Given this list of marker genes GAB1, HGF, GRB2, PIK3CA, PIK3R1, MET, here is a description of the gene set: MET binds and phosphorylates the adapter protein GAB1, thus creating a docking site for the regulatory subunit PIK3R1 of the PI3K complex. Recruitment of PI3K to MET-bound phosphorylated GAB1 results in PI3K activation, production of PIP3, and stimulation of downstream AKT signaling. Reactome Pathway: MET activates PI3K/AKT signaling species: Homo sapiens part of: Signaling by MET